Given this list of marker genes Alox12, here is a description of the gene set: This event has been computationally inferred from an event that has been demonstrated in another species.<p>The inference is based on the homology mapping from PANTHER. Briefly, reactions for which all involved PhysicalEntities (in input, output and catalyst) have a mapped orthologue/paralogue (for complexes at least 75% of components must have a mapping) are inferred to the other species. electronically inferred by orthology from the curated human pathway studied in species Mus musculus part of: Biosynthesis of DPAn-3 SPMs Reactome Pathway: Biosynthesis of DPAn-3-derived maresins